The following is a description of a gene set: The mechanisms involved in downregulation of TCF-dependent transcription are not yet very well understood. beta-catenin is known to recruit a number of transcriptional repressors, including Reptin, SMRT and NCoR, to the TCF/LEF complex, allowing the transition from activation to repression. CTNNBIP1 (also known as ICAT) and Chibby are inhibitors of TCF-dependent signaling that function by binding directly to beta-catenin and preventing interactions with critical components of the transactivation machinery. Chibby additionally promotes the nuclear export of beta-catenin in conjunction with 14-3-3/YWHAZ proteins. A couple of recent studies have also suggested a role for nuclear APC in the disassembly of the beta-catenin activation complex. It is worth noting that while some of the players involved in the disassembly of the beta-catenin transactivating complex are beginning to be worked out in vitro, the significance of their role in vivo is not yet fully understood, and some can be knocked out with little effect on endogenous WNT signaling (see for instance Voronina et al, 2009). Reactome Pathway: Deactivation of the beta-catenin transactivating complex studied in species Homo sapiens part of: TCF dependent signaling in response to WNT, and this is the list of marker genes: TLE1 (TLE family member 1, transcriptional corepressor), KMT2B, UBB, HDAC1, PYGO1 (NCBI Gene Id 283658), TCF7L1, CTNNB1 (catenin beta 1), TLE4, CBY1, ASH2L, TLE2, PYGO2, TCF7, MEN1, SOX4, SOX9, UBC, DPY30, SOX17, BCL9L, TLE3, YWHAZ, CTNNBIP1, SOX2, BCL9, SOX3, SOX6, XIAP, SOX7, AKT1, SRY, WDR5, CTBP1, XPO1, RPS27A, BTRC, LEF1, SOX13, CHD8, UBA52, APC (NCBI Gene Id 324), RBBP5, AKT2, TCF7L2